Given this list of marker genes CRYAB, EPHA2, ZBTB20, PITX3, ITM2B, APC, VIM, BBS2, here is a description of the gene set: Human Gene Set: HP_POSTERIOR_POLAR_CATARACT A polar cataract that affects the posterior pole of the lens. species: Homo sapiens Posterior polar cataract